Given this list of marker genes Dkc1, Sertad4, Rictor, Cebpa, Hus1, Ugdh, Pld5, Slc37a1, Pcdh19, Epha10, Hbs1l, Chpt1, Usp28, Hepacam2, Pcdhb10, Bbs5 (Bardet-Biedl syndrome 5), Rnf14, Zswim4, Dennd1b, Lmx1a, Eif2s1, Galnt3, Hivep2, Cbl, Camk4, Eloc, Mecp2, Pabpc5, Adamts5, Plxna1, Htr2c, Ap1s3, Vwc2l, Fibin, Hecw2, Syncrip, Thrap3, Otud7b, Selenof, Gucy1a2, Ebag9, Gm7073, Fam117b, Sc5d, Hycc2, Cdh8, Trib2, Nt5e, Cep76, Yod1, Ccpg1, Fdx2, Mcm5, Miga1, Cept1, Smim13, Igf1, Sh2b1, Pappa, Trmt12, Zbtb41, Phb2, Ocln, Kcnh2, Dmac2l, Msi2, G3bp2, Snx13 (NCBI Gene Id 217463), Serbp1, Cetn1, Erc2, Garre1, Mb21d2, Atp8b2, Nck2, Zfp14, Paip1, Spin4, Lcorl, Tmem186, Hectd1, D430041D05Rik (NCBI Gene Id 77092), here is a description of the gene set: species: Mus musculus from publication Chen Y, Wang X (PMID 31504780) Mouse Gene Set: MIR_6924_3P Genes predicted to be targets of miRBase v22 microRNA mmu_miR_6924_3p in miRDB v6.0 with MirTarget v4 prediction scores > 80 (high confidence targets).